The following is a description of a gene set: Mouse Gene Set: MIR_300_5P species: Mus musculus Genes predicted to be targets of miRBase v22 microRNA mmu_miR_300_5p in miRDB v6.0 with MirTarget v4 prediction scores > 80 (high confidence targets). from publication Chen Y, Wang X (PMID 31504780), and this is the list of marker genes: Btbd10, Siglec1, Glud1, Otc, Srr, Scaf11, Zfp36l1, Ddx19b, Mmp12, Actn1, Lypd8, Zfp97, Bcat1, Epha3, Tnfsf4, Mmp8, Wee1, Large1, Fbxw7, Rpn2 (NCBI Gene Id 99280), Arl6ip6, Ppp1r16b (NCBI Gene Id 277461), Fam120a, Folr2, Fhip2a, Kif5c, Dclre1c, Prkg2, Hlf, Igf2r, Ppm1b, Duox1, Lrch2, Cdkn2aip (CDKN2A interacting protein), Zbtb24, Sgsm2, Prame62, Kcns3, Appl1, Adarb2, Lin28b, Csde1, Rlig1 (RNA 5'-phosphate and 3'-OH ligase 1), Scarf1, Mtcl2, Zfp781b, H2-M10.5, Klhl4, Map3k1, Pik3cg, Pramel3c, Epc1, Itm2b, Krtap9-22 (keratin associated protein 9-22), Zng1, Khdc4, Tmem106b, Krtap9-3, Jarid2, H2bc24, Krtap4-2, Plagl2, Slc35f5, Asah2, Pgk2, Fam163b, Ms4a1, Trim16, Rab10, Adgrb1, Usp1, Gabrb2, Aspn, Tgm6, Slc25a53, Clec2m, Zbtb11, Prss23, Spcs1, Terb1, H2-M10.1, Ulk2, Ccdc90b, Zfp595, Rfx3, Zdhhc21, Rfx2, Snu13, H2-M10.6 (histocompatibility 2, M region locus 10.6), Sema3d, Sorcs1, Fbxo11, Rcn2, Ccdc122, Tmem108, Ccdc28b, Trappc3, Atxn1, Rps6ka6, Elavl1, Heca, Ccnb1, Dhx40, Suclg2, Cdhr3, Arih2, Trib2, Samd13, Spink8, Zfp960, Pde2a, Pramel3b, Rspry1, Asph, Rbm27, Snapc5, Dennd4c, Prok2, H2bc23, Ttc5, Emc3, Tor1aip2, Ppm1l, Edil3, Rbm18, Pnma3, Med27, Zmynd8, Tafa1 (NCBI Gene Id 320265), H2-M10.3, Ppil2, Hnf4g